Given this list of marker genes PROZ, ICA1L, MAP3K14, CYP4F3, TSHZ2, PAN2, RCL1, LMOD3, MLXIPL, ITSN1, BCO2, TEAD1, CLMN, MYO1B, TNRC6A, PCDHB1, DNAJA1, ZNF283, NFX1, AHI1, MST1, ZNF397, CYP2C9, LINC00887, LEPR, CYP2B6, LONP2, GADD45G, CCNL2, HPX, SNAP29, ACAD11, PCDH11Y, SHROOM1, MPV17L, AIG1 (androgen induced 1), IDH2, ASGR1, C6, BDH1, F7, SNORD3A, ARIH2OS, YIF1B, RBL1, NUGGC, SDS (NCBI Gene Id 10993), RANBP10, FEM1A, CSAD, CXCL1, SLC43A2, AP1M1 (adaptor related protein complex 1 subunit mu 1), SEC23A, RBBP5, WNT2B, UTP23, IL1RAP, PPP1R12B, KIZ-AS1 (KIZ antisense RNA 1), CRP, SORL1, UBR4, DDI2, PCAT7, ITIH1, POLR2J3, GPR82, LINC00895, MFAP5, INSIG1, DNAJC22, BCDIN3D, CA5A, HEATR5A, MTMR9, CMC2, ZNF101, TENT5A, MKLN1-AS, ASPG, AFM, SVOP, ELL2, MAVS, PABPC1L, OLAH, XKR4, GPAM, DIS3, ACSL1, ZFAND5, CYP3A43, HGFAC, ENPP1, TJP2, FTCD, GCGR, APMAP, AR, RHOBTB3, DDR1-DT, C15orf40, PNPLA3, PDP2, CFHR3, DESI1, RPS27L, DDX10, PPARA, ZC3H13, DST (dystonin), LRRC27, FAM20A, PCK1, H6PD, PAH, TLCD4, PLEKHA2, AASS, TAF8, CLNK, MKNK2, LINC01285, KIF1C, SGSM1, ZNF556 (zinc finger protein 556), ABCA5, HAO2, PLIN4, CPEB4, CCBE1, SH3PXD2A, COBLL1, ZNF639, ITGA9-AS1, ZNF426, HAL, NTRK3, RN7SL391P, HLF, NDUFV3, KCNA7 (potassium voltage-gated channel subfamily A member 7), SERAC1, LACTB2-AS1, A1CF, HELB, COL27A1, ZKSCAN1, C8A, RUNDC1, CCDC30, RN7SL602P, NOS1AP, PTP4A1, LRCH3, HPN, SIN3B, ULK1, GPT2, TUT7, CYP3A4, TMEM87A, ACER3, MIGA1, CHORDC1, PHKA2, GABPB2, TAT, KLF6, SLC25A37, MUC3A, CYP2A13, SLC35E3, FMN1, AIPL1, EMC10, RN7SL605P, MAST4, ARSK, ZNF641, DCPS, VSIG1, PHF6, RNF115, FOXO1, A2M, PPP6R2, IKBIP, ADCY1, GTPBP10, PHACTR4, ID2, GCKR, SLC13A5, PROX1, TRMT9B, BHMT2, FMO5, NAA16, SUGP2, TNFSF14, ZNF419, C4BPB, SLC23A2, CAMK1D (calcium/calmodulin dependent protein kinase ID), EFNA1, UBN2, CYB561A3, LINC01209, BHMT (betaine--homocysteine S-methyltransferase), SRSF11, CMKLR2-AS, SEMA3E, ERRFI1 (NCBI Gene Id 54206), AK3, LUADT1, RN7SL134P, METTL2B, TNFAIP8L1, LEAP2, XPR1, HSPA4L, LRRC58, ABLIM3, C1R, FMO3, SLC25A13, LINC00963, SLC14A2, STEAP4, MACC1, VEGFA, RNF41, SLC39A14 (NCBI Gene Id 23516), ZNF154, TMEM192, UBE2G2, COMMD2, MLXIP, ARHGEF26, FBXO21, TRIM72, NBPF11, MAS1, FAM161A, NCBP3, GTF2H2, PLGLB1, METTL21A, SCML1, RN7SL202P, NBPF12, GNE, TLCD2, FBXO31, CYP2C19, FOXO3, FKBP5, ZNF554, SLC28A2, HEMK1, PNPT1, SIK2, GFOD2, ZBTB25, HDHD3, F12, EXOC3-AS1, LINC01116 (NCBI Gene Id 375295), COL18A1, ANGPTL4, SLC25A16, ZNF454, CHRD, FHL2, SLC7A2, POR, RAD54L2, TMEM254-AS1, MOGAT3, NNT-AS1, PTK6, ADGRG6, LINC01554, CYP2D6, LINC01502, NLRP12, ARG1, DSG2, GLYCTK, CFH, FBXO22, GABPB1-AS1, FST (NCBI Gene Id 10468), NEDD9, GRTP1, SLCO1B3, HAP1, UCKL1-AS1, SLC31A1, FBXO48, NR1I2, LYRM7, RN7SL403P, CAPN3, ZMAT3, QSOX1, GRB14 (NCBI Gene Id 2888), RN7SL510P, C2orf68, ALDH1L1, SELENBP1, CPS1, SRD5A1, ABCC2, FBXO17, CCT8, WDR31, ZNF605, GTF3C2-AS2, IL6R, MTO1, IDS, SLC25A18, CP, ABCA6, FBXL18, PPP1R3B, VSTM4, AGXT, TMEM106A, MDM2, RAMP2-AS1, ITPR2, ZHX3 (zinc fingers and homeoboxes 3), VHL, INE2, ABCC3, TENM1, LRP6, SLC17A9, RNF216, RSPH3, ASL, L1TD1, C5, ABHD15, ST3GAL6, CCDC142, ARHGEF10L, ATF3, GGPS1, GSDMB, SGMS1-AS1, PPARGC1A, CEP89, ONECUT2, STAT3, RALGAPA2, DSG3, NNT, FAXC, ITIH3 (NCBI Gene Id 3699), CYP2C8, ARMC9, BIVM, CNKSR3 (NCBI Gene Id 154043), ZNF264, PTAFR, COLEC12, SELENOO, INTS6, SLC27A2, GTF2H2C, PDE6A, PCLAF, BCL6, ERBB3, BAAT, KCNMB1, PDE4DIP, MAT1A, RPS6KA5, RN7SL811P, ABCA1, C17orf75, LSINCT5, MREG, YIPF4, MEGF9, LINC00574, ZYG11B, PART1, KPNA6, PEDS1, DSTYK, RIOK3, C5AR2, DGKH, LRRC57, ADGRA3, ACSM2A, PIK3C3, SEC14L4, TTC38, MFSD4B, PROC, GNL3L, DHTKD1, IRS2, ARL10, IYD, PHF8, GMEB1, GTDC1, KREMEN1, PPP2R1B, GOLGA8B, CYP3A5, PCYT1A, EPHX2, STXBP5-AS1, FYB2, PNISR, NSUN6, KIR3DX1, CHDH, ACSM5, PTPN3, ACACB, PLIN5, TUBD1, IGFBP1 (insulin like growth factor binding protein 1), ALAS1, F5, MIRLET7BHG, FAM98B, ACADVL, LINC01521, RN7SL274P, MEG8, ECHDC2, RAB27A, ADPRHL1, HGD, here is a description of the gene set: studied in species Homo sapiens from publication Aizarani N, Saviano A, Sagar, Mailly L, Durand S, Herman JS, Pessaux P, Baumert TF, Grün D (PMID 31292543) Human Gene Set: AIZARANI_LIVER_C30_HEPATOCYTES_4